The following is a description of a gene set: from publication Chen Y, Wang X (PMID 31504780) Human Gene Set: MIR4728_5P Genes predicted to be targets of miRBase v22 microRNA hsa-miR-4728-5p in miRDB v6.0 with MirTarget v4 prediction scores > 80 (high confidence targets). studied in species Homo sapiens, and this is the list of marker genes: DRG2, ERI3, SUPT5H, RELT, RPL15, AGPAT1, PLCXD1 (NCBI Gene Id 55344), TRAPPC9, TTYH3, MINK1, CD6, ALPG, RNF38, CLSPN, IQSEC1, KIF21B, ATXN2L, ANKRD45, BAZ2B, TAF4, HOXA1, CSF1R, GNL3L, CBX6, SYN2, KLRC3, MYO1C (NCBI Gene Id 4641), TMTC1, ATP7A, MPP2 (NCBI Gene Id 4355), PNMA2, HIPK2, TAPBP, ZNF674, PTK2, ATP1B2, PPARD, GAB2, SHISA7, KIF18B, DACT1, PGAM4, ELK1, COL6A1, COL5A3, TBKBP1, CSDE1, VSIR, CLIP2, FCAR, NRF1, ZCCHC8, NFIC, ABCB8, XPNPEP3, DEPDC5, PLAGL2, TNS1, CYP26B1, NATD1, RAB37, CCDC43, ZNF333, KY, MIEF2, DDAH1, ADAM12, RHOB, ARHGEF11, TRIM67, POU2F1, MTX3, NTSR1, BICDL1, EIF4EBP2, GAL3ST3, C1orf210, B3GAT3, ABHD14B, MRPL43, CLCC1, SCAMP4 (NCBI Gene Id 113178), PIK3R2, PNPLA6, MEF2D, CDR2L, GNAO1, PTGR3, ARL17A, FAM120B, BORCS8, AHDC1, ZNF544, DAAM2, DLGAP4, MTA2, COPS7B, KSR2, F11R, DNAJB2, STARD9, DAB2IP, RFT1, DDX11, ARMC9, PRMT1, DTX4, CIT, NBL1, KCTD10, MDC1, MXD3, ZNF490, NDST1, PITPNM3, MAFF, PDE7A, IGSF8, SULT1C4, ZNF814, CSNK2A1, JPH1 (junctophilin 1), SYT15, TIMP3, ELAVL1, DAGLA, PPIA, ZBTB4, ZNF649, PXMP4, N4BP1, POU2F2, LRP1, TFAP2B, CNGA2, PARVG, TPBGL, TMEM276, PLA2G4E, CEBPZOS, XYLT1, PPP1R9B, MYH14, SFXN3, PITPNM2, FNIP1, MXRA7, VPS37C, GPM6B, TCF3, ARNT2, PPM1F, GANAB, ARHGDIA, PRICKLE1, SOX12, FOXP4, CPQ, LZTS3, SYNJ1, SMU1, SMPD3, TNS2, SLC2A4, EXPH5, ANGPT4, PTPRJ, SYNGR1, NACC1, FANCF, FBXL18 (NCBI Gene Id 80028), HDAC2, TMEM252, TNK1, TUBB4A, FIBCD1, ABO, XKR6, CASTOR2, IKZF3, SLC29A3, GRSF1, GLDN, PLXNA4 (plexin A4), CHP1, MEX3A, ERAL1, PSMB2, SCAI, CCDC180, TRAPPC14, SPRY4, COL11A2, AGAP2, IQSEC3, MVB12B, ALX4, BCL9, PACS1, ATF7, MPDU1-AS1, DUSP4, POLH, SEC22B, RAB35, NUTM2G, HK1, TSKU, ARHGAP23, MMP19, HCFC1, LYN (LYN proto-oncogene, Src family tyrosine kinase), SETDB1, ABCG4, TET3, SUFU, TMEM104, PIGR, HOOK3, STIM1, GALNT2, KCNK15, FBXL20, SLC35F6, PACSIN1, LENG8, CSDC2, MS4A4A (NCBI Gene Id 95933), NF2, BET1L, SAMD10, PXDC1, SYT7, PBX2, SHISA6, BAZ2A, AP2A1, CSF1, ERF, NUP98, SV2A, APOL6, RNF44, VPS25 (vacuolar protein sorting 25 homolog), ZFAND5, STK25, DESI1, KIF19, CAMK1, AP1S1, PNPLA2, PCBD2, NLGN3, DBNDD2, HAP1, HYI, SARM1, TAP1, OLFML1, RALGDS, DDX18, RAVER1, TAF10, DES, DPF1, HSPB7, SLC34A2, BCL2L1, PNPO, SMG6, GRK2, RPH3AL, ADAM19 (NCBI Gene Id 8728), AVPR2 (NCBI Gene Id 554), YBX2, PLA2G2A (NCBI Gene Id 5320), PHYHIP, SCGB2B2, ANKRD63, DUSP8, ZNF503, MYADM, RPL32, TMEM120B, IFFO2, RAB30, CCL22, SLC25A23, CTSD, MYO10, ABCD1, PAIP2B, GCDH (glutaryl-CoA dehydrogenase), CHST3 (NCBI Gene Id 9469), SLC7A1, FAIM2, GNAT1, KRTAP4-11, PKNOX2, TSPAN18 (tetraspanin 18), TOMM40, PGAM1, PDK2, HMGXB3, RPRD2, TFDP2, LINC03040, RAD51B, ARHGEF12, CYP4V2, KIAA1549, NFASC, APOA5, ARFRP1, TCTN2, FAT2, FLT4, SH3GL1, CSMD2, PFN2, SERPINA1, INKA2, APRG1, SBF1, ACP3, TFEB, SAV1, NGFR, RBMS2, RAB11B, SMARCD1, MLLT6, PRKCA, HOXC4, SYNGAP1, CREB3L2, SLC8A2, MRTFA, RNF222, TMEM184B, LRFN1, KCND3, SRRM4, PPM1J (NCBI Gene Id 333926), RSPO4 (R-spondin 4), ZNF548, YWHAQ, CARM1, ATP2A3, MTF1, KRT75, CERCAM, ENTPD3, MBOAT2, THTPA, FUS, CCDC69, MKNK2, CYP1A2, NHERF2, SV2C, BMP8A (NCBI Gene Id 79787), ZNF518B, ZNF385A, PURA, FGFR1OP2, ABCC12, EDNRA, MAVS, LRRC4B, MECP2, GSK3A, NAV2, RNMT, FURIN, CORO2B, RNF24, LRRC51, PPP5D1P, SH3BP2, PRR12, ATP8A2, CBLN3, EFCAB2, MTFMT, USP37, MTCL2, MAPK13, UTP11, KHSRP, SENP5, C9orf78 (chromosome 9 open reading frame 78), RAB5B, SDK1, RHOC, APLNR, ARPC4-TTLL3, ABCB5, HOXA10, PTPRB, GFOD2, TPCN1, PRR30, SREBF2, TOLLIP, ATXN1, MGRN1, AR, KCNIP1, RIMS3, SCN1B, FOXK1, AGAP1, TGFBR3L, NPTX1, ORAI2, TMEM63C, WBP2, SLITRK5, RRP15, ATOSB, CSF2RB, RBFOX2, RHO, RALB, NECTIN1, GGCX, CAPZB, EEIG1, SUSD5, ADGRL1, ASIC1, MNT, RARA, RASSF5, POLR1G, YPEL4, STX1A, UNC5B, APOBEC3F, SLC6A11, GPR65, FAM131B, KIF5A, RBM24, ELAVL3, CASP10, NOVA2, VSIG10L, PEX2, GPRC5A, PRR32, GDI1 (NCBI Gene Id 2664), CALN1, MTR, CDKN1A, WDTC1 (NCBI Gene Id 23038), VWA5B2, POU2AF1, NPTXR, FAM3D, SPI1, AQP6, MOB3A, SCN4B, GRM4, SHANK1, IL2RG, PRG4, NOX1, MDM4, STK35, OAF, ZNF609, CASKIN1, ELFN2, CDC42BPA, SELENON, ZSCAN30, NOL9, NIBAN2, PAPOLG, ADCYAP1R1, PDLIM2, FKBP1B, SLC25A45, ENTPD2, BSN, SLC4A8, COMMD6, PCBD1, GLP1R, GLG1, NCOR2, PLEKHA5, ZNF710, PIK3C2B, POLR2E, KCNQ4, CIC, PTPRA, MYRF, SORCS1, POMT2, NYNRIN, STX2, SYP, RTN3, G6PC3, DNAJB12, C20orf96, WNT9B, TMED4, ANKRD52, MAP3K9, C1QTNF6, ACKR2, ZNF667, MGAT5B, IRGQ, GRIP2, MAPT, FSCN1, SDC3, ZNF384, PTPN3, RAB3IL1, C2CD2L, MORC4, SOX13, ALPL, HOGA1, DNM1, NOS1, RAP1GAP2, S100A5, KCNE5, DLK1, TMEM94, KCNQ2, PARP11, SSBP3, VAMP2, SLC12A4, EEF2K, EYA3, THY1, HOXB8, NFIX, C1RL, DDA1, CDC23, CNNM1, KLC2, ME2, VAT1, DPF3, SPN, ADAM21, B9D1, FBXO10, PA2G4, SLC22A23, APCDD1, RUSC1, SLC7A8, ARPC2, NPAS3, FAM131C, RPS6KA2